Given this list of marker genes UTY, NAA15, SSH2, IRAK1BP1, CKAP2L, UBE2G2, DNAJA3, IMPACT, ELOVL5, HHEX, ESYT3, ADAM17, KCNJ13, PCDHB4, OPRM1, ZNF483, TANK, ZNF462, ZC2HC1A (zinc finger C2HC-type containing 1A), SRSF2, STAG2, RCAN2, FNDC3A, EML1, HNRNPUL2, GM2A, ZNF479, EYA1, YWHAE, TBCA, DDX3X (DEAD-box helicase 3 X-linked), PSME3IP1, KCNH8, SRSF11, ZNF765, FBXO28, PPP2R5A, PCYOX1 (NCBI Gene Id 63081), SYT16 (synaptotagmin 16), NSD2, TMEM106B, KIAA1217, SLITRK4, SLC39A4, ATMIN, MARCHF7, ZNF493, SLC46A1, NOP58, LIPA, NR2F2, SPZ1, ZNF107, POU4F1, TP63, DDX3Y, ALDH3A2, ZNF140, SLA, CHN2, GREM1, GABRG2, FUBP3, SOCS5, ZNF117, ZNF28 (NCBI Gene Id 7576), WDHD1 (WD repeat and HMG-box DNA binding protein 1), RAB27B, TCP11L2, TSPAN13, here is a description of the gene set: Human Gene Set: MIR4464 studied in species Homo sapiens from publication Chen Y, Wang X (PMID 31504780) Genes predicted to be targets of miRBase v22 microRNA hsa-miR-4464 in miRDB v6.0 with MirTarget v4 prediction scores > 80 (high confidence targets).